The following is a description of a gene set: Interferon Signaling Human Gene Set: REACTOME_INTERFERON_SIGNALING species: Homo sapiens, and this is the list of marker genes: KPNA1, IFNA16, MAVS, B2M, TRIM22, PTAFR, HSPA2, IFITM1, EIF2S2, FANCC, ADAR, IFNA14, TUBAL3, HSPA5, UBE2L6, CENPX, HLA-DPA1, HLA-DRB3, GBP3, IRF6, TRIM35, NUP214 (nucleoporin 214), SP100 (SP100 nuclear antigen), TUBB4B, HLA-DRB5, PTPN2, HLA-DQB2, DHX9, TUBB2B, RNASEL, FANCM, MAPT, TP53, IRF9, RAE1, IFIH1, TRIM10, OASL, NUP153, PPP2CA, TUBA4A, NUP42, PPM1B, IFI6, NUP107, SNCA, OAS1, IFNA17 (interferon alpha 17), NPM1, ICAM1, TRIM29, TUBA1A, PTPN11, KPNB1, HLA-B, STAT2, IFI27 (NCBI Gene Id 3429), EIF2AK2, EGR1, CHUK, TRIM17, TUBB2A, CAMK2A (NCBI Gene Id 815), IFIT2, OAS2, OAS3 (2'-5'-oligoadenylate synthetase 3), PPP2R1B, ARIH1, IFNA7, POM121, CAMK2G, NUP98, SOCS1 (NCBI Gene Id 8651), IKBKG (inhibitor of nuclear factor kappa B kinase regulatory subunit gamma), GBP4, NUP62 (NCBI Gene Id 51551), HLA-DRB1, TUBB8B, UBA52, IFNA5, RSAD2, BECN1, TRIM2, TRIM8, TRIM68, FANCL, TRIM62, TRIM48, IFNA4 (interferon alpha 4), FCGR1A, PPP2CB, NEDD4, TUBA1C, STAT3, NCAM1, EIF2S1, HLA-DPB1, IFNA21, NUP50, HLA-DQA1, IFITM3, MAP2K6, BST2, CAMK2B, FLNA, MAPK1, TUBA4B, EIF4G3, EIF2AK3 (eukaryotic translation initiation factor 2 alpha kinase 3), RIGI, EIF4E3, TRIM38 (NCBI Gene Id 10475), NUP58, IFI30, TRIM6, UBB, IFNA10, NUP54, PPP2R5A, PSMB8, HSPA1B (NCBI Gene Id 3304), FAAP24, IFNA1, IFNA2, NUP210, VCAM1, MID1, PTPN1, RPS27A, TUBB1, HLA-F, ILF3, TUBA1B, TUBA3E, NUP205, HSPA1A, NUP160, PML, CD44, NCK1, UBE2E1, EIF4A2, PIAS1, ABCE1, TARBP2, PDE12, NUP85, GBP6, NUP188, FAAP100, EIF4G2, PLCG1, ISG20, MAPK3, TUBB3 (tubulin beta 3 class III), ILF2, TRIM26, IFI44, TUBB8, HLA-E, UBE2N, SPHK1, UBE2I, EIF4G1, IRF1, FAAP20, FANCB, UBA7, YBX1, PRKCD, STAT1, SUMO1, EIF4E, MX1, USP18, IFNGR1 (interferon gamma receptor 1), IRF2, HLA-DRB4, HLA-DQB1, TRIM46, FANCA, IP6K2, SMAD7, NUP155, DUS2, IRF5, SAMHD1, IFIT1, EIF4A3, NUP35, ATF6, EIF4A1, TRIM14, EIF4E2, SEH1L, JAK2 (Janus kinase 2), MT2A, IRF7, KPNA5, NUP37, TUBA8, FKBP5, PTPN6 (NCBI Gene Id 5777), KPNA3 (karyopherin subunit alpha 3), EIF2S3, UBC, TRIM31 (NCBI Gene Id 88008), ISG15, HLA-H, SOCS3, TUBB4A, IFNAR2, KPNA7, KPNA2, PPP2R1A, CIITA, HSPA8, TRIM34, GBP2 (guanylate binding protein 2), CENPS, IFNA13, IFIT5, GBP1 (NCBI Gene Id 2633), HERC5, NUP93, IFI44L, RAF1, HLA-G, TYK2, FANCE, TRIM3, GBP7, IFIT3, IFNGR2, TRIM5, IFI35, NDC1, FLNB, HLA-DRA, CDK1, IKBKB, TUBB6, HLA-A, CAMK2D, HSPA1L, IRF8, TUBA3C, POM121C, TUBA3D, TRIM21, PRKRA, PIN1, RANBP2 (RAN binding protein 2), TRIM45, IRF4, IFNAR1, HLA-C, JAK1, TPR, IRF3, IFNA8 (NCBI Gene Id 95818), AAAS, IFNA6, XAF1, FANCF, DNAJC3, IFITM2, TRIM25, IFNG, NUP133, FCGR1BP, NUP43, HLA-DQA2, NUP88, FANCG, MX2, KPNA4 (NCBI Gene Id 84857), GBP5 (NCBI Gene Id 115362), SEC13, IFNB1